The following is a description of a gene set: Mouse Gene Set: GOBP_ALCOHOL_CATABOLIC_PROCESS The chemical reactions and pathways resulting in the breakdown of alcohols, any of a class of compounds containing one or more hydroxyl groups attached to a saturated carbon atom. studied in species Mus musculus, and this is the list of marker genes: Sult2a1, Sult2a8, Adh4, Sord, Nudt3 (nudix hydrolase 3), Ntsr1, Akr1d1, Sult1b1, Cyp7a1, Srd5a3, Sult2a7, Tpi1, Scarb1, Aldh3b1 (NCBI Gene Id 67689), Gk, Sult2a6, Cyp27a1, Akr1c18, Hao1, Tkfc, Adh1, Sult2a5 (sulfotransferase family 2A, dehydroepiandrosterone (DHEA)-preferring, member 5), Hsd3b7, Adh7, Pten, Aldh1b1, Adh5, Sult2a2, Gk5 (glycerol kinase 5), Cyp39a1, Aldh2, Sult2a4 (sulfotransferase family 2A, dehydroepiandrosterone (DHEA)-preferring, member 4), Miox, Gk2, Aldh1a7, Sult1e1 (sulfotransferase family 1E, member 1), Apoe, Cyp46a1, Aldh3b2, Gpd2, Sult2a3 (NCBI Gene Id 638199), Synj2